Given this list of marker genes RAB43, ALS2CL (NCBI Gene Id 338373), PSD3, ATP8A2, EDEM1, ADAMTS14, C2orf49, PTCHD4 (NCBI Gene Id 442213), RAP1GAP, RBM20, UBE2QL1, KCNK9, GRIK3, DOCK3, BCL2L13 (NCBI Gene Id 25779), RFTN1, PIP4P1, KAZN, KIRREL3, ADD2, LMX1A, ARID3B, TIMM22, SH3TC2, ETV5, RGP1, ZNF239, ZDHHC3, PTPN12, HSPB7 (NCBI Gene Id 27129), TMEM47, SLC6A3, TRMT112, DHDDS, SLC38A4, TMEM184A, PRKAR2A, AFF3, KLK15, MXI1, MYO1B, CHGA, RNF4, PAX3, TXNRD1, IST1, ADCY1, IGFBPL1, TP53INP2, CEP89, PBX1, USP46, LHX1, DDN, TBCEL, VASH1, TEF, FAM53C, COX6C, TMEM131, LIMD2, YEATS2, POP1, KATNIP, ZBTB39, PRR12, BLTP2, FGF3, TRIM9, SLC12A5, HEYL, KCNQ1, SH3BP5L, UNK, SYNJ1, ELOVL5, LPAR5, NUP58, KDM4A, LMO4, EPHB2, SH3PXD2A, CASZ1, NSMF, ELAPOR2, TMEM114, MMP28, SMNDC1, SNX12, MSRB3, BSN, HTR2C (5-hydroxytryptamine receptor 2C), NUFIP2, DSE, PLEKHB2, EPHA10, CASTOR2, LHFPL6, PRDM1, ZNF710, GPR132, FHIP2A, CIMIP1, PHLPP1, TRAPPC3L, here is a description of the gene set: Genes predicted to be targets of miRBase v22 microRNA hsa-miR-3173-5p in miRDB v6.0 with MirTarget v4 prediction scores > 80 (high confidence targets). studied in species Homo sapiens Human Gene Set: MIR3173_5P from publication Chen Y, Wang X (PMID 31504780)